Given this list of marker genes PRKAG1, HSPA4L, POGLUT1, ASH1L, RPS6KA5, SPATS2L, PHF20L1, PDXK, RC3H2, GNL3L, COMMD10, CCNI (NCBI Gene Id 10983), ADIPOR2, RBPJ, DNM1L, ITGB5, EXPH5, RAD17, DHX32, ARPC2, GUCY1B1, MDH1, PSMA7, LGALS8, DHTKD1, SMAD1, LMBRD1, FBXO11, RTCB, DAB2, DPP8, SELP, MMRN1, NOVA1, EMSY, TRIM44, GUCY1A1, RPL7A, PSMD1, ABCC3, KLF6, CLEC4A, ZNF318, BPTF (bromodomain PHD finger transcription factor), DUSP3, TBC1D5, PDE8A, COL21A1, C21orf91, DENND4C, TMEM50A (transmembrane protein 50A), ATP5F1C, MR1, GDAP2, CPQ, RBMS1, ITPR2 (NCBI Gene Id 3709), CD53, CCDC121 (coiled-coil domain containing 121), CEMIP, RPS6KA3, NCOA1, ARHGEF12, AHCYL1, GCNT1, FAM114A1, METTL9, YIPF6, GTF2H1, PIAS1, DENND1B, CLDN6, MINDY2, SPOP, RAB9BP1, CHD9, IFI44L, GABARAPL2, MICU1, STXBP5L, SELENOP, ANXA2P2, OSBPL1A, PSMC1, PTER, GSTO1, MCTP1, COPA, TANK, ATP6V1E1, STAT3, RNFT1, CLOCK, SERF2, PUS3, TBC1D19, CPS1, SAP18, GGPS1, RNF41, XK, TPTE, ATP2B4, GMFG, AFTPH, GFOD2, PRKCB, ZNF586, PARP8, ADK, CYP7A1 (NCBI Gene Id 1581), SYT11, MPHOSPH6, KIAA0586, STX18, XAF1, PSMC2, AP3B1, CYP2C19, TMF1, EPS8, MFAP3L, SAV1, RPL12, LEPROT, RAB3GAP2, USP9X, MSH3, RAB11FIP2, MGST3, TUBD1, CLIC2 (chloride intracellular channel 2), PURA, CRK, GART, UBE2L3, ASAP1 (ArfGAP with SH3 domain, ankyrin repeat and PH domain 1), ESD, CNOT1 (NCBI Gene Id 51579), MTF1, STRN (NCBI Gene Id 6801), SON, FOXC1, TRPC4 (NCBI Gene Id 7223), CDC40, UGP2, NIT2, MRPS22, PSMA1, ANXA2, TNFSF10, CSTPP1, KCTD20, KLF7, REL, DAZL, ARL6IP5, CALCOCO2, VCL, RBBP6, GDI2, ASAP2, VPS35, KPNA3, PCNX1, CLTC, EBLN2, ROCK2, PAPSS2, TNFSF4, LHFPL6, ZNF133, LPP, STRADA, CASP1, OXA1L, GNAQ, RUFY2, GNPAT, L1TD1, ANXA4, TAX1BP1, RHEB, SPARC, SCAMP1, LAMTOR5, EIF2S2, SRGAP2, SCAF4, TOM1L1, ACSL5, ARHGAP15, FBXO9, SLC17A5, TIA1, ADGRE1, UVRAG, F13A1, MOB4, here is a description of the gene set: from publication Kaizer EC, Glaser CL, Chaussabel D, Banchereau J, Pascual V, White PC (PMID 17595242) studied in species Homo sapiens Human Gene Set: GSE9006_TYPE_1_VS_TYPE_2_DIABETES_PBMC_AT_DX_DN Genes down-regulated in peripheral blood mononuclear cells (PBMC) from patients with type 1 diabetes at the time of diagnosis versus those with type 2 diabetes at the time of diagnosis. Objective: We hypothesized that type 1 diabetes (T1D) is accompanied by changes in gene expression in peripheral blood mononuclear cells (PBMCs) due to dysregulation of adaptive and innate immunity, counterregulatory responses to immune dysregulation, insulin deficiency and hyperglycemia. Research Design and Methods: Microarray analysis was performed on PBMCs from 43 patients with newly diagnosed T1D, 12 patients with newly diagnosed type 2 diabetes (T2D) and 24 healthy controls. One and four month follow-up samples were obtained from 20 of the T1D patients. Results: Microarray analysis identified genes differing in expression between newlydiagnosed T1D patients and controls at a false discovery rate of 0.05. Changes in expression of interleukin-1β (IL1B), early growth response gene 3 (EGR3), and prostaglandin-endoperoxide synthase 2 (PTGS2) resolved within four months of insulin therapy and were also observed in T2D suggesting that they resulted from hyperglycemia. With use of a knowledge base, 81/genes could be placed within a network of interrelated genes with predicted functions including apoptosis and cell proliferation. IL1B and the MYC oncogene were the most highly-connected genes in the network. IL1B was highly overexpressed in both T1D and T2D, whereas MYC was dysregulated only in T1D. Conclusion: T1D and T2D likely share a final common pathway for beta cell dysfunction that includes secretion of interleukin-1β and prostaglandins by immune effector cells, exacerbating existing beta cell dysfunction, and causing further hyperglycemia. The results identify several targets for disease-modifying therapy of diabetes and potential biomarkers for monitoring treatment efficacy.